Given this list of marker genes Ap4e1, Dusp2, Itpripl1, Gm14244, Ptpra, Adra1d, Hdc, Gm14048, A530010F05Rik, Secisbp2l, Ciao1, Vps16, Tgm6, Gm14023, Gm14042, Shc4, Gm14028, Mir103-2, Snord110, Spef1, Snord57, Erv3, Mertk, A730036I17Rik (RIKEN cDNA A730036I17 gene), 1810024B03Rik, Prom2, Gm14280, Tmem239, 4930583P06Rik, Cops2, Slc20a1, Gfra4, Cpxm1, Tmem127, Dnaaf9, 4930473A02Rik, Zfp661, Gm14049, Gm23101, Gm14003, Slc4a11, Sppl2a (signal peptide peptidase like 2A), Gm14004, Stk35, 4930517E11Rik, Idh3b, Slc12a1, Mrps26, Siglec1, Ckap2l, Ubox5, Pank2, Vinac1, Dtwd1, Dut, Cenpb, Gm4430, Rnf24, Spdye4c, Chchd5, Adissp, Gm14283, Mtln, 1700020A23Rik, 5330413P13Rik, Mall, Mrps5, Ctxn2, Cdc25b, Gm24665, Gm22424, Gm14281, Lzts3, Gm14007 (predicted gene 14007), Mir3473g, Pced1a, Gm14245, 4933427J07Rik, Snrpb, Gm14046 (NCBI Gene Id 545463), Bcl2l11, Avp, Gm14010, Morrbid, Ddrgk1, Fam227b, Gm14024, Slc27a2, Gm27003, Snrpert, Itpa, Gm24451, Polr1b, Gm14057, Gm14026, Gpat2 (glycerol-3-phosphate acyltransferase 2, mitochondrial), Gm23650, Fbln7, Gm10766, Il1b, Gm10774, Stard7, Gm23187, Cep152, 9830144P21Rik, Mavs, Gm14041, Gm14040, Usp8, Tmem87b (transmembrane protein 87B), Zc3h6, Sema6d, Adra2b, Eid1, 9530056E24Rik, Adam33, Anapc1, Spcs2-ps, Bub1, Gm39929, Ttl, Oxt, Pdyn, Il1a, Slc24a5, Gm14285, AU015228, Mal, Ap5s1 (NCBI Gene Id 99307), Nphp1, Tmc2, Ebf4, Tgm3, Mir6339, Gm9913, Gm14232, Gabpb1, Astl, Gm14006, Gm14229, Gm22889, Acoxl, Hspa12b, Usp50, Kcnip3, Fastkd5, Galk2, Myef2 (myelin basic protein expression factor 2, repressor), F830045P16Rik, Ncaph, Zc3h8, Gm14304, Fgf7, Blvra, Sirpa, Fbn1, A730017L22Rik, Fahd2a, Nop56, Gm14044, Trpm7, Il1bos, Gm25703, Atp8b4, Mir6973b, Smox, Gm14022, Snrnp200, Gm14002, Gm14008, Gm29010, Atrn, Gm14009, here is a description of the gene set: studied in species Mus musculus Mouse Gene Set: chr2F1